Given this list of marker genes ANGPTL3, NRIP1, SREBF1, RXRA, FASN, NR1H3, RXRB (retinoid X receptor beta), SCD, NR1H2, here is a description of the gene set: species: Homo sapiens Human Gene Set: REACTOME_NR1H2_NR1H3_REGULATE_GENE_EXPRESSION_LINKED_TO_LIPOGENESIS NR1H2 & NR1H3 regulate gene expression linked to lipogenesis